Given this list of marker genes DENR, GCLC, GRK6, PGRMC2, EEFSEC, HNRNPR, EPS15, ITGB1BP1, PWP1, CDR2, HNRNPDL, GPX6, CARMIL1, TMX1, MTF2, PSMA8, ARL1, RPAP3, MMP8, MOB4, IDH1, DIS3, DHRS1, ELOVL1, METAP2, MYO1B, SEPHS2, CTBP2, ABCB10, IL36G, DGKZ, ATP6V0B, CLEC4A, EIF4B, FAM50A, CYB5R1, DYNLRB1, RAB14, RPRD1A, EIF3A, HSBP1, NTPCR, GPR180, FKBP15, CALU, SARNP, ATP1A3, YAE1, TIMM17B, GORASP1, JAG1, PMS2, RGS19, PRDX1, MCM7, NUP85, ARL6, MYADM, EMC10, SLAIN2, RPS27L, MICOS13, HOXC13, NSDHL, CHEK2, HSP90B1, S1PR1, SEPTIN7, ARHGAP24, ARHGDIA, NUDCD1, TIMM50, POLR2H, MCM2, SRSF10, PLAUR, STAMBPL1, TRIM59, DNAJB6, SEC61B, POLR2E, ADSL, WNK4, TMEM165, SAP18, TPTE, MTRR, COQ9, GABARAP (GABA type A receptor-associated protein), GLRX3, MAP3K8, SNRPD2, RPIA, PMP22, PRSS35, MTDH, ANP32A, SAMM50, GPS1, SREBF1, RRN3, ACSS2, MRPL12, ACTR6, SRP14, NCF2, ACADM (NCBI Gene Id 51779), C19orf53, CLUH, IDH2, EXOSC10, DRG1, SDHC, FTH1, NUP210 (nucleoporin 210), MRPL21, MYLIP (myosin regulatory light chain interacting protein), DHX15, JAGN1, AP3S1, LRRC59, LYPLA2, CS, MFSD10, ZNRD2, MPND, SLC35A1, MRPS7, FCGR2A, NCBP2, CX3CR1 (C-X3-C motif chemokine receptor 1), MFSD14A, IMPDH2, SYNJ2, DOLPP1, DRG2, MVK, GLMN, WDR83OS, GRK2, PHYKPL, ARHGEF1, SUCLA2, LMO4, CDC34, EBPL, NABP2, TSKU, UTP18, DDB1, RPL23A, PDE8A, SLCO3A1, S1PR5, SORT1, ADORA2B, RETREG1, SLC7A13, SPRYD7, ECI2, PBDC1, TSR2, ITGAL, PRPF8, SLC25A10, IL1RAP (interleukin 1 receptor accessory protein), KIF3C, NUDT2, TRPV2, BTG2, SNRPG, RNF187, ARCN1, HSP90AA1, GGH, ITSN1, NOA1, COX6C, CLCC1, UFM1, SEMA4A, MYL6, TIMM10, GTF2B, ZMYM1, JADE1, CTU1, AOAH, PDXDC1, AKR1B1, MARCHF6, MMUT, RWDD4, PREB, EMC7, KCNA3, ATP5MC1, SLC41A2, SRSF6, NAA60, here is a description of the gene set: from publication Amit I, Garber M, Chevrier N, Leite AP, Donner Y, Eisenhaure T, Guttman M, Grenier JK, Li W, Zuk O, Schubert LA, Birditt B, Shay T, Goren A, Zhang X, Smith Z, Deering R, McDonald RC, Cabili M, Bernstein BE, Rinn JL, Meissner A, Root DE, Hacohen N, Regev A (PMID 19729616) studied in species Homo sapiens Genes down-regulated in comparison of dendritic cells (DC) stimulated with poly(I:C) (TLR3 agonist) at 12 h versus DC cells stimulated with Pam3Csk4 (TLR1/2 agonist) at 12 h. mouse primary BMDCs were stimulated with tlr ligands and gene expression changes were profiled on Affymetrix arrays Human Gene Set: GSE17721_POLYIC_VS_PAM3CSK4_12H_BMDC_DN